Given this list of marker genes Pde3a, Grin2b, Edn1, Lpar1, Ramp3, Crh, Sfn, Iapp, Gpr3, Prkar1a, Scn11a, Spatc1l, Mc1r, Ucn, Pde4a, Prkar2b, Lrrk2, Adcyap1, Adipoq (adiponectin, C1Q and collagen domain containing), Adgrv1, Sesn2, Adrb2, Calcr, Pde10a, Ednra, Prkaca, Pkia, Pde4d, Gip, Creb1 (cAMP responsive element binding protein 1), Prkar2a, Rps23rg1, Mif, Atf1, Prkar1b (protein kinase, cAMP dependent regulatory, type I beta), here is a description of the gene set: An intracellular signaling cassette that starts with production of cyclic AMP (cAMP) by adenylate cyclase (either transmembrane or soluble), which activates protein kinase A, and ends with activation of downstream effectors such as the transcription factor CREB that further transmit the signal within the cell. species: Mus musculus Mouse Gene Set: GOBP_CAMP_PKA_SIGNAL_TRANSDUCTION